Given this list of marker genes XRCC4, ATP23, NHEJ1, XRCC5, LIG4, XRCC6, PRKDC, here is a description of the gene set: Human Gene Set: GOCC_DNA_DEPENDENT_PROTEIN_KINASE_DNA_LIGASE_4_COMPLEX species: Homo sapiens A large protein complex which is involved in the repair of DNA double-strand breaks and, in mammals, V(D)J recombination events. It consists of the DNA-dependent protein kinase catalytic subunit (DNA-PKcs), the DNA end-binding heterodimer Ku, the nuclear phosphoprotein XRCC4 or a homolog thereof, and DNA ligase IV.